Given this list of marker genes IL1B, COPZ1, PLPPR2, PPP1R16B, PPARGC1B, NDFIP1, KCNE4, PHF12, CACNG7, APOLD1, RUFY2, TNRC6B, TNFRSF12A, DDX4, DACH1, ESRP2, PCDH7, KCNJ12, LONRF1, TBX15, CLCA1, SLC25A27, PCBP4, KCNJ18, ZNF362, FBLN1, B4GALT2, CUX1, here is a description of the gene set: species: Homo sapiens from publication Chen Y, Wang X (PMID 31504780) Genes predicted to be targets of miRBase v22 microRNA hsa-miR-4313 in miRDB v6.0 with MirTarget v4 prediction scores > 80 (high confidence targets). Human Gene Set: MIR4313